The following is a description of a gene set: studied in species Mus musculus Mouse Gene Set: GOBP_AMPA_GLUTAMATE_RECEPTOR_CLUSTERING The glutamate receptor clustering process in which alpha-amino-3-hydroxy-5-methyl-4-isoxazole propionate (AMPA) receptors are localized to distinct domains in the cell membrane., and this is the list of marker genes: Snx27, Apoe, Ssh1 (slingshot protein phosphatase 1), Dlg4, Shank3, Shisa7, Grip2, Zdhhc2, Slc7a11, Nlgn1, Chrdl1, Frrs1l, Shisa6, Lrrtm4